Given this list of marker genes LZTR1, PTPN11, MAP2K1, DYM, AHDC1, XYLT2, BRAF, SRCAP (NCBI Gene Id 10847), TBX5, POP1, KRAS, WNT4, TRAPPC2, CHST3, RAB5IF, FUCA1, TRPV4, IDH1 (NCBI Gene Id 3417), here is a description of the gene set: Shield chest Human Gene Set: HP_SHIELD_CHEST studied in species Homo sapiens A broad chest.